The following is a description of a gene set: studied in species Homo sapiens Human Gene Set: GNF2_HDAC1 Neighborhood of HDAC1 Neighborhood of HDAC1 histone deacetylase 1 in the GNF2 expression compendium, and this is the list of marker genes: SRSF4, NACA, TAF7, PAPOLA, SRSF10, DDX50, HNRNPU, EIF3D, DDX46, PABPN1, FAM111A, POP5, ABT1, FBL, TARDBP, AIMP1, SLC7A5P1, DDX18, OXA1L, DDX39B, SF3B1, SRSF1, SRRM1, SF3A1, PNRC2, CLK2, PSMA1, TRA2B, NONO, ZCCHC8, UXT, HNRNPM, ZNF207, YTHDC1, PDS5A, HNRNPC, CDC40, UTP3, SRSF3, RBM39, TAPBP, U2SURP, FNBP1, EED, EIF2S3, HNRNPR, HNRNPDL, RPS3, SART3, SNRPD3, NOL11, RPL34, PSME2, KPNB1, HNRNPK, PSMB8, SNRNP200, EIF4B, GTF3A, EIF2B1 (NCBI Gene Id 1967), SS18L2, SF3B2, RPL22, HNRNPF, YY1, TTC31, RBM10, OSR1, TENT4A, RPF1, EXOSC8, TIAL1, MCM3AP, SMARCA5, SF1, DAP3, TRA2A, RPS7, DDX47, SUMO2, CBFB, ANKRD49 (ankyrin repeat domain 49), IFT25, SCAF11, ZBTB1, CSK, RPS23, ELAC2, SRSF7, KHDRBS1, UBP1, IFI16, MAGOH, UBE2D2, HNRNPA3P1, CNOT7, BTF3, COPS7B, DHX15, RBMX (RNA binding motif protein X-linked), RNF138, CDK5RAP1, NDUFA1, RBBP6, ZC3H15, SRSF2, CCDC59, RNF4, HDAC1, RBM15